The following is a description of a gene set: Neighborhood of ICAM3 intercellular adhesion molecule 3 in the GNF2 expression compendium Neighborhood of ICAM3 species: Homo sapiens Human Gene Set: GNF2_ICAM3, and this is the list of marker genes: GMFG, CASP4, TUT7, RIN3, HSD17B11, ICAM3, GPSM3, LST1, HLA-G, TXNIP, HLA-E, PSTPIP1, ITGB2, EVI2B, SLA, APOBR, ARHGAP25, RIPOR2 (NCBI Gene Id 9750), ADAM8, EMP3, GIT2, PTPRC, DPEP2, IRF1, SELL, ARRB2, HLA-F, HCLS1, TMEM127, DAZAP2, ACAP2, FMNL1, PTPN6, GMIP, MYO1F, WAS, STAT6, SH3BGRL3, MAX